The following is a description of a gene set: studied in species Homo sapiens Human Gene Set: MIR6870_5P Genes predicted to be targets of miRBase v22 microRNA hsa-miR-6870-5p in miRDB v6.0 with MirTarget v4 prediction scores > 80 (high confidence targets). from publication Chen Y, Wang X (PMID 31504780), and this is the list of marker genes: FKBP8, MEX3A, COL9A2, TNFSF12, TFAP2B, SPIN3, SPRR1B, AP2M1, NHERF2, CELF3, PRR23A, SLC8A2, RERG, PPP2R2D, CNTNAP1, APLNR, SNPH, NKAIN1 (sodium/potassium transporting ATPase interacting 1, NCBI Gene Id 79570), PCDHB11, THRSP, PLXNA4, AFAP1, ACSL5, MAP1A, BSN, TMEM63B, CNST, PDLIM4, CTNND1, FGF1 (NCBI Gene Id 29961), PPT2, ATAD3C, CHRNA4 (cholinergic receptor nicotinic alpha 4 subunit), GAS7, KALRN, GRIN1, PKNOX2, SLC28A1, LRRC28, MLLT6, TBC1D10B, PANX2, ITGA3 (NCBI Gene Id 4454), ZNF691, C6orf141, ZBTB7B, SF3A2, IKZF4, MTCL2, FOXE1, NFIC, CNIH2, MAT1A (NCBI Gene Id 4143), TREML1, BSDC1, FAM131B, KCNJ10, ZFC3H1, DUSP10, CADM4, VPS37D, DIRAS1, UBE2QL1, MECP2, ZNRF2, SLC7A8, STAC2, KMT2D, SNX29, MIEN1, GRHL2, RBM23, GPRC5A, SCGB2B2, HEYL, ADRA1A, UBTF, COTL1, MFRP, PLVAP, GPAT4, NAPA, APBA1, PSMF1, GTPBP2, PIK3R2, PRC1, CLSTN1, SYNGAP1, EPB41L1, GATAD2B, CYP2B6 (NCBI Gene Id 82059), FAM234A, PPP2R1A, NFASC, MYL12A (myosin light chain 12A), SLC8A1, POU2F2, TCF7, PRKACA, PDE1B, PACS1, CCDC102B, VAMP2, NFIX, EN1, JPH4, CES4A, LRATD2, SZRD1, MPZ, INAVA, UBAP2L, IGSF11, CAMK1D, ACTB, DVL3, ELAVL3, METTL9, C9orf57, CD1C, FOXC1, H1-10, SERPINB7, DMWD, PAX5, WNT3, ELK1, ANKRD26, RAB11FIP4 (NCBI Gene Id 85018, RAB11 family interacting protein 4), SHISAL1 (shisa like 1), SH3TC2, ZDHHC15, CALR, CHPF, LRRC59, NR1D1, CAMKK2, CXADR, URM1, IL17RD, NOVA2, STIM1, WNK4, CCDC97, WIZ, HMGA1, SMARCC2, RBMS3, ATP9A, CASTOR2, CTDSP1, LIX1L, DYRK1A, CDR2L, PPP1R9B, TMEM198, DDX31 (NCBI Gene Id 64794), PTHLH (NCBI Gene Id 5744), ADORA3, MED19, TMEM151A, FAM174B, SLC6A17, PPP2R5E, SHANK2, XYLB (xylulokinase), MNT, DPYSL5, RANBP10, C19orf12, DIRAS2, PVALB, PRR5L, TMEM222, IHH, CDK18, LCE1B, ST13, BMP1, SLC9A8, MAP7D1, KCNC3, FBXO43, MTSS2, LRP8, ANKRD52, TCP11L1, SH3PXD2A, DEF8, FOXP4, NAT16, FADS2 (fatty acid desaturase 2), SIRPB1, CPS1, BIRC2, TRAM2, TLE3, MINK1, ARRB2, PIP5K1C, LSAMP, NLGN2, ALX4, TMEM54, SLC25A42, NRG1, SOX13 (NCBI Gene Id 9580), PHLPP1, RSU1, DYSF, SRF, PHC2, PLA2G2D, PSME3